Given this list of marker genes Mtnr1b, Cnr1, Ptger1, Tbxa2r, Ptger3, Ptger2, Lpar1, S1pr2, S1pr1, Ptafr, Ptgir, Ptgfr, S1pr4, Ptgdr, S1pr3, Cnr2, Ptger4, Mtnr1a, here is a description of the gene set: Mouse Gene Set: WP_GPCRS_SMALL_LIGAND species: Mus musculus GPCRs, small ligand